The following is a description of a gene set: species: Homo sapiens Human Gene Set: REACTOME_TRANSCRIPTIONAL_REGULATION_BY_RUNX3 Transcriptional regulation by RUNX3, and this is the list of marker genes: EP300 (E1A binding protein p300), CREBBP, PSMD3, PSMC5, JAG1, PSMA6, NOTCH1, MDM2, PSMA7, PSMB1 (NCBI Gene Id 5689), SMURF2, MAMLD1, PSMD8, RORC, CDKN2A, UBC, TCF7L1, PSMA5, CBFB, PSMB4, TEAD3, UBB, PSMD13, SNW1, WWTR1, PSMD14 (proteasome 26S subunit, non-ATPase 14), ADRM1, CTNNB1, TEAD4, BCL2L11, ZFHX3, PSMB6, SRC, PSMA3, PSMD7, FOXO3, RBPJ, PSMB3, PSMB2, KAT2B, CCN2, UBA52, PSMC4, KAT2A, SMURF1, PSMA1, LEF1, PSMD11, MAML2, RPS27A, KRAS, BRD2, SMAD3, PSMD12, HDAC4, HES1, TGFB1, SPP1, MAML3, RUNX1, CCND1, PSMD1, ITGA4, PSMB5, PSMD6, CDKN1A, TEAD1, TP53, TEAD2 (TEA domain transcription factor 2), SMAD4, MYC (NCBI Gene Id 731404), PSMB7, PSMA4, RUNX3, SEM1, PSMD2, TCF7, PSMC1 (proteasome 26S subunit, ATPase 1), PSMC3, PSMC6, TCF7L2, ITGAL, PSMA2, MAML1, YAP1, PSMC2